The following is a description of a gene set: A homeostatic process involved in the maintenance of a steady state level of amino acids within a cell. Human Gene Set: GOBP_INTRACELLULAR_AMINO_ACID_HOMEOSTASIS species: Homo sapiens, and this is the list of marker genes: TPP2, KCTD7, ACACB, SLC66A1, SLC7A11, GLS, SLC1A1, GRM2, SLC38A3